The following is a description of a gene set: Human Gene Set: GOCC_GTPASE_COMPLEX A protein complex which is capable of GTPase activity. studied in species Homo sapiens, and this is the list of marker genes: RRAGC, GNB4, GNGT2, GNG8 (G protein subunit gamma 8), GNG7, GNG10, GNAT1, GNB2, GNB5, GNAI3, GNB3, GNAO1 (NCBI Gene Id 2775), GNAT3, GNG11, GNGT1, GNAI1, GNAZ, GNG3, GNG2 (G protein subunit gamma 2), SOS1, GNG13 (G protein subunit gamma 13), GNAQ, GNG12 (NCBI Gene Id 55970), GNG14, GNA11 (NCBI Gene Id 93626), GNAT2, GNA15, RRAGB, RRAGA, RRAGD, GNG4, GNA14, HRAS, GNG5B, GNA12, GNAI2, GNAL (NCBI Gene Id 2774), GNB1, GNA13, GNAS, GNG5